Given this list of marker genes UCHL1, GBA2, PRKCG, REEP2, SPART, KCND3, SPAST, AMPD2, ALDH18A1, XK, B4GALNT1, ABCD1, CACNA1G, here is a description of the gene set: A decrease in the ability to perceive vibration at the ankles. Clinically, this is usually tested with a tuning fork which vibrates at 128 Hz and is applied to the malleoli of the ankles. species: Homo sapiens Human Gene Set: HP_IMPAIRED_VIBRATION_SENSATION_AT_ANKLES Impaired vibration sensation at ankles